The following is a description of a gene set: species: Homo sapiens Mutations in the kinase domain (KD) of TGF-beta receptor 1 (TGFBR1) have been found in Ferguson-Smith tumor i.e. multiple self-healing squamous epithelioma - MSSE, breast cancer, ovarian cancer and head-and-neck cancer. KD mutations reported in MSSE are nonsense and frameshift mutations that cause premature termination of TGFBR1 translation, resulting in truncated receptors that lack substantial portions of the kinase domain, or cause nonsense-mediated decay of mutant transcripts. A splice site KD mutation c.806-2A>C is predicted to result in the skipping of exon 5 and the absence of KD amino acid residues 269-324 from the mutant receptor. The splice site mutant is expressed at the cell surface but unresponsive to TGF-beta stimulation.<br><br><br>TGFBR1 KD mutations reported in breast, ovarian and head-and-neck cancer are missense mutations, and it appears that these mutant proteins are partially functional but that their catalytic activity or protein stability is decreased. These mutants are not shown. part of: Loss of Function of TGFBR1 in Cancer Reactome Pathway: TGFBR1 KD Mutants in Cancer, and this is the list of marker genes: SMAD3, SMAD2, TGFBR1, TGFB1, TGFBR2, ZFYVE9